The following is a description of a gene set: Human Gene Set: HP_MUSCLE_WEAKNESS Reduced strength of muscles. species: Homo sapiens Muscle weakness, and this is the list of marker genes: PMP22, NFE2L2, TBCD, EEF1A2, NEFH, ERCC8, PCNA, MINPP1, TRMU, TAF15, SGCG, SYNE1, VDR, TAMM41, MT-CO3, VWA1, BOLA3, DGUOK, HADHA, NABP1, ADSS1, CNBP, EARS2, GBF1, VARS2, SLC39A14, COL5A2, MEGF10, SMN1, SVIL, COL9A1, PRORP, WARS2, BTD, ITPR1, PNKP, XRCC1, SETX, NTNG2, MT-ND3, SOX10, NUP54, SLC1A2 (NCBI Gene Id 6506), RRAS, AARS1, ADGRG1, CYP27A1 (cytochrome P450 family 27 subfamily A member 1), MT-TL2, SORD, ERBB4, ALAS2, NF1, ARSA, DMP1, ABHD5, ACBD5, SZT2, AMER1, FXR1, CNTNAP1, PEX3, SLC25A1, PSMB8, OPA1, FAM111B, HTT, POMT1, COA8, TRPV4, BMP6, TFG, VMA21, MAP2K2, DPM2, TACR3, SPTLC1, DUX4, ARMC5, ATP7B, LIG3, DHDDS, IDS, ATP2A1, SLC12A3, MTM1, COL4A1, CNOT1, ABCD1, PEX19 (NCBI Gene Id 7835), LYRM7, CYP11B1, NDUFAF4, NDUFV1, C9orf72, GRIN1, MYOT, ABCA2, SLC2A3, COL6A3, TWNK, PIEZO2, MYH3, GNB1, FBXO28, TTPA, PLP1, MUSK, GRIA3, MTMR14, FUS, COL9A3, BVES, SLC25A26, CLCN1, NDE1, TNR (tenascin R), GFER, NTRK2, TRAPPC11, SGCA, PIGA, KCNJ18, PTS, PUS1, TCIRG1, POPDC3, LIMS2 (LIM zinc finger domain containing 2), NECAP1, FBLN5, TOP3A (DNA topoisomerase III alpha), TPM2, PGM2L1, CNKSR2, CLCNKA, KY, NDUFAF3 (NCBI Gene Id 375340), LYRM4, SLC5A6, SCN11A, LRP5, CDC73, LDB3, TRMT1, KCNJ2, UBA2 (NCBI Gene Id 10054), SFRP4, PLIN4, SURF1, BIN1, TREX1, TGFB1, ATP5F1D, SPR, GTPBP2, EBF3, ETFDH, COL1A1, SELENON, SLC12A1, SCNN1A, XYLT2, DSTYK (NCBI Gene Id 353293), MYF6, NEK1, EHHADH, MRAS, SLC25A19, ATRX, MT-ND5, RNASEH1, NIPA1, TRIM32, ATP5F1E, EXOSC9, HINT1, MYPN, MYBPC1, CRLF1, DUSP6, ERCC6, L1CAM, KCNE3, PIK3CA, AIFM1, TTN, MCM3AP, WDR11, GCH1, RXYLT1, MFN2, POLR3A, LRP4 (LDL receptor related protein 4), SLC12A6, NDP, FLAD1, SLC25A12, ZNF526, MFF (NCBI Gene Id 56947), DPAGT1, ACTL6B, EXOSC3, ATXN3, GNB5, MLX, EXOSC5, UQCRFS1, COL12A1, SUPT16H, CLTC, RUSC2, NKX2-1, FEZF1, MT-CO2, CPLANE1, RFXAP, MTTP, MYMX, GAN, SPTA1, UBQLN2, GOSR2, SCN2A, SMPD1, DPM3, DHH, GABBR2, BTNL2, AGTPBP1, PTEN, STAC3 (SH3 and cysteine rich domain 3), GDAP1, P4HA2, ETFA, PNPLA6, KCNC2, NONO, SCN8A, DES, PUF60, DNAJC19, TNFRSF11B, CACNA2D1, MTHFR, CHRNB1 (NCBI Gene Id 1140), KLHL41, PIGQ, SEPTIN9, FOXC2, CDKN2A, SPART, PDE11A, KMT2D, HSPB8, SLC7A7, GCK, OPTN, SOS1, POMGNT1, MT-TP, PEX2 (NCBI Gene Id 5828), TCAP, PEX26, ENPP1 (ectonucleotide pyrophosphatase/phosphodiesterase 1), DLL4, ANTXR1, CD59, SLC34A3, LAMP2, VRK1, OAT, NAA80, DNAJB2, GJC2, GSN, SPEG, ERLIN2, CYP27B1, ATP1A1, B4GALNT1, RRM2B, SACS, TEFM, AK9, EXTL3, SOS2, SIGMAR1, MT-TI, MT-TS2, SPG11, HCN1, LRP12, COQ8A, FXYD2 (FXYD domain containing ion transport regulator 2), IMPDH2, HNRNPA1, ACOX1 (acyl-CoA oxidase 1), EIF2AK3, CHRND, PI4KA, SPTLC2, PEX12, PRPS1, VPS50 (VPS50 subunit of EARP/GARPII complex), REEP1 (NCBI Gene Id 65055), ALS2, EMILIN1, DALRD3, DDC, HARS1, GFAP, POLG, CYP2R1, PPOX, MSTO1, HAMP, KARS1, GFPT1 (glutamine--fructose-6-phosphate transaminase 1), DKK1, DNA2, APTX, KIF1A, MTAP, SCYL1, GNAS, NFU1, KCNJ5, CCDC141, IL12B, PAX7, IRF4, NDUFS4, VARS1, NBN, MYL2, GAA, CLP1, LBR, CHRNE, SPG21 (NCBI Gene Id 51324), NUMA1, PEX10, DCC, SIK1, VCP, ALG13, MMUT (NCBI Gene Id 4594), CACNA1S, WWOX, SRPK3, NDUFAF2, MYL1, IBA57, SLC18A2, INPP5E (inositol polyphosphate-5-phosphatase E), HMBS, SCNN1G, MT-ATP6, PHEX, AAAS, COL13A1, FUCA1, VAMP1, SLC32A1, RAF1, KRAS, ANOS1, PHKA2, CAMLG, ARX, NARS2, ETFB, NDUFS7, CDK19, ATPAF2, MRPL12 (NCBI Gene Id 6182), DMPK, ABCB6, KLHL9, STAG2, PNPLA2, CACNA1B, REV3L, DAO, NDUFS3 (NCBI Gene Id 4722), PTRH2, CHCHD10, BMS1, TMEM63A, TIMM50, GABRA2 (gamma-aminobutyric acid type A receptor subunit alpha2), TMEM165, PEX5, ISCU, SRPX2, COX6A1 (cytochrome c oxidase subunit 6A1), SCYL2, NDUFAF5, TK2, RYR3, PABPN1, ACTA1, ATXN2, SLC26A4, COX6B1, SLC19A3, HS6ST1, CAPRIN1, SERPING1, COL9A2, CPT1C, EIF2B3, YME1L1, ATP13A2, PAFAH1B1, TTC19 (tetratricopeptide repeat domain 19), TPM3, KCNA1, PTPN11, RANBP2, IRAK1 (NCBI Gene Id 3654), GRM7, HACD1, NEUROD2, IFIH1, NEU1, PRPH, TCN2, ASCC1, TRAPPC6B, SECISBP2, SBF1, ANKH, KBTBD13, RNF170, PIGP, NOD2, ALDOA, POLRMT, SNAP29, ADAR (adenosine deaminase RNA specific), MRPS2 (NCBI Gene Id 64972), EIF2B2, UBA1, ADCY6, LIPE, FDX2, SDHAF1, CASQ1, AR, SLC13A5, TNNT1, SPRY4, PIK3R5, FBN1, MT-ND2 (mitochondrially encoded NADH:ubiquinone oxidoreductase core subunit 2), TBCE (NCBI Gene Id 6905), FLNC, TUBB6, SLC34A2, C19orf12, IRF5 (interferon regulatory factor 5), STIM1, HK1, MT-TN, STAT4, SPG7, ANO5 (anoctamin 5), SLC22A5, HSPD1, GPI, SAT1, POLG2, SYT2, POGLUT1, CCND1, NDRG1, CCM2, DARS2, SLC25A42, CYP7B1, NUBPL, BET1, SPARC, PEX7 (peroxisomal biogenesis factor 7), RALGAPA1, COQ2, CHRNA1, NDUFA10, COX6A2, ATXN1, PON1, D2HGDH, SIX5, CPLX1, TRPM7, RARA, FIP1L1, MRPS25, LARGE1, MICU1, FOXRED1, TRDN, PRNP, CCDC174, TTR, AGK, NR3C1, KIF5A, SIX1, HMGCR, CASR, MT-TQ, MT-ND1, SYNGAP1, RYR1, SEMA3A, IFRD1, GATM, GPHN, MT-ND6, MPZ, UQCC3, SLC9A7, TRMT5 (tRNA methyltransferase 5), DYM, MFSD2A, COA7, CYP11B2, TYMP, JAG1, SLC39A8, NDUFA1, CDH23, IREB2, CHP1, PDGFB, ESAM, SLC33A1, EMD, PHKG1 (NCBI Gene Id 5260), KCNJ10, FKRP, SUFU, DMD, CAPN3, GRIN2D, RFC1, MORC2, MT-ND4, HLA-DRB1, MEN1, BAG3, BRCC3, EPB42, SCN1A, ATP5F1A, AHDC1, GEMIN4, FRG1 (FSHD region gene 1), MT-TH, SGCD, MT-CO1, SLC16A2, NDUFAF6, COX20, TNXB, HESX1 (HESX homeobox 1), KCNJ1, RBCK1, MYMK, PPP1R15B, SNAP25, SMARCB1, MT-TE, FLI1, GARS1, CPOX, MPV17, CADM3 (NCBI Gene Id 57863), SNUPN, RETREG1, RARS1, SMCHD1, PTDSS1, PLOD1, PDXK, MYH7, RAPSN, PTPN22, RTN2, NOP56, PIGN, PSAP, TSFM, AGRN, SLC25A46, CAV3, PFN1, PRRT2, SUCLG1, GYG1, MECR, FIG4, ALAD, ADCY5 (adenylate cyclase 5), GABRB2, PHYH, HADHB, LTBP4, TRH, RASA2, CCR6, DHX16, IGHMBP2 (NCBI Gene Id 50985), MGME1, ASAH1, ATP1A2, SLC25A22, CYFIP2, TERT, SPAST, JAG2, PAX8, PYGM, PEX6, DSE, PEX13, NRAS, ADPRS, CDKL5, KPNA3, PDK3, TAFAZZIN, USP48, HEXB, COL25A1, AMPD1, PEX11B, SMN2, HNRNPK, CLDN16, ITGA7, BICD2, GNE, JPH1, IFT140, RAB7A, COL5A1, COQ7, WARS1, DNMT1, TPI1, FARS2, MT-ATP8, SLC25A20, KCNA2, COL1A2, MT-TK, ORAI1, STAT3 (NCBI Gene Id 6774), AARS2, PHKA1, AP3D1, ASPA, ACADM, GMPPB, GNA11, PHKG2, SARDH, RAI1, MT-TW, TDP1, NAGA, PHKB, PNKD, PLEKHG5, B3GALNT2, NDUFS8, PRX, TIMMDC1, BICRA, GGPS1, CASP2, COQ4, YARS1 (NCBI Gene Id 8565), SCO2, SLC25A24, FGD4, ATL1, MATR3, IL17RD, COX10, HEXA, NDUFV2, GABRA5, SLC25A21, HNRNPDL, SDHB, CHMP2B, DNM1, ATP9A, SYNE2, AKT1, NPM1, LRIF1, TSHR, PLXND1, PREPL, ACTN2, COG8, GFM2, HNRNPA2B1, CFAP410, LRSAM1, PET100, SARS1, HLA-B, PML, PMM2, UBAP1, SQSTM1, DNMT3B, CPT2, NF2, AHCY, PEX16, POMGNT2 (protein O-linked mannose N-acetylglucosaminyltransferase 2 (beta 1,4-)), NUTM2B-AS1, CHST14, NEB, PON3, ANG, AGL, SLC5A7, CASK, SMO, KLHL40, CAVIN1, SMPX, CNTN1, FKBP14, MTRFR, FGF17, HFE, TOR1AIP1, TRAF7, ASCC3, ITGB4 (integrin subunit beta 4), STAT5B, GJA1, CHD7, SPTAN1, PMPCA, TOR1A, TRAK1, PYROXD1, LGI4, PGAP2, GBE1, SUCLA2, ABCC8, SDHD, GLT8D1, GNB4, TBL1XR1, PON2, FZR1, SH3TC2, EGR2, STAT1, COL6A1, LAMA2, DOK7, SLC18A3 (solute carrier family 18 member A3), PTRHD1, PACS2, ATP13A3, CRYAB, NDUFA6, NDUFAF1, COL6A2, FGF23, SGCB, NDUFA11, SPTB, LITAF, TIA1, CCN6, VAPB, SOD1, VPS13D, KCNB1, TNPO3, LZTR1, LPIN1, GNB2, KRIT1, DYNC1H1, MYH2, ATP5MK, SMARCAL1, DNAJB6, NR4A2, COX4I1, ANK1, AFG3L2, RNU12, GRIN2A, NDUFB9 (NADH:ubiquinone oxidoreductase subunit B9), CACNA1A, SPTBN2, ADNP (activity dependent neuroprotector homeobox), ADK, PFKM, OSTM1 (NCBI Gene Id 28962), POMK, FLVCR1, INPP5K, HIVEP2, ATG7, CPT1A, RIT1, PGK1, SALL4, ELP2, SYNJ1, PMP2, LMOD3, MLIP, NDUFS6, DDHD2, NDUFS1, DCAF8, FA2H, SLC4A1, SNX10, XRCC2, TANGO2, PLA2G6, FGFR1, HPRT1, SBF2, ANXA11, AMPD3, NDUFAF8, CELF2, ASL, YY1, AP3B2, SOST, YWHAG, PGM1, CEP126 (centrosomal protein 126), EYA1, CBL, SHMT2, UFC1, VHL, TARDBP, DDHD1, POLR1A, POLR3GL, ZFTA, BCOR, KCNJ11, SPTBN4, CCN2, PLAA, LRPPRC, GJB1, AP2S1, ALG14, PMPCB, EXOC8, PROKR2, CTNNB1, POU3F4, ATXN7, SPP1, MME, TNNC2, KDM1A, NKX2-5, NDUFS2, PNPLA8, ATP6V1E1, ATP6V1A, UNC13A, CFL2, UBE2T, DNM2 (dynamin 2), DNAJB4, TRIM2, HLA-DQB1, CAMK2B, HSPB1, LMNB1, FGF8, RARS2, LAMB2, TFAP2A, BSCL2, ZNRF3, COQ6, HSD17B10, NDUFA13, RASA1 (NCBI Gene Id 5921), FGF12, UBA5, PDCD10, GNPTAB, FHL1, ACY1, MYO9A, TBCK, NDUFB10, PROK2, GABRA3, MAPT, FKTN, SEMA3E, MED25, BRAF, XK, CLCN7, COLQ, NACC1, ALG2, CCNF, RPS6KA3, CLCN2, ITPR3, MIEF2, DHTKD1, FBXL4, DCTN1, SPRED2, ALDH18A1, CACNA1G, ABHD16A, CHAT, BCS1L, PRKACA, ACAD9, TRIM8, SCN3A (NCBI Gene Id 6328), NDUFA8, ZFYVE26, WASHC5, SCN4A, PARS2, ATL3, RRAS2, IRF2BP2, UBE3B, NUS1, NAGLU (NCBI Gene Id 4669), FLRT3, ERGIC1, FOXG1, CHKB, SLC34A1, POMT2, SLC25A4, NOTCH2NLC, MDH2, MT-TV, VPS13A, MYH14, CAPN1, DAG1, MARS1, HOXB1, TBK1, SIL1, CLCNKB, OBSCN, FXN, B4GAT1, TUBB3, TMEM126B (NCBI Gene Id 95018), FMR1, SLC38A3, FBXO38, SDHA, ZBTB16, DOLK, UNC45B, DYSF, USP8, TMEM43, SLC35A2, AP5Z1 (NCBI Gene Id 9907), GBA2 (glucosylceramidase beta 2), EXOSC8, KIF1B, SLC52A3, DUX4L1, NADK2, RNF31, BSND, MT-TF, PNPT1, MICOS13, TREM2, NDUFB11, PPP3CA, KLHL24, HSPB3, FOXE1, NUP62, NDUFB3, TRMT10A, GABRG2, TRIP4 (NCBI Gene Id 9325), HJV, PEX1, CAV1, CNNM2, ZC4H2, LEMD2, HSPG2, DHFR, DMXL2, ATP5MC3, GLE1, ATP7A (ATPase copper transporting alpha), YARS2, MTMR2, PEX14, PLEC, GALC, ELOVL5, GM2A, NSUN3, CCDC78, SKI, SMARCE1 (NCBI Gene Id 6605), SLC52A2, GIPC1, FILIP1, NGLY1, SCNN1B, NDNF, ABCA1, BAP1, PRKAR1A (protein kinase cAMP-dependent type I regulatory subunit alpha), PHACTR1, ADA2, TGM6, NEFL, KCNK9 (NCBI Gene Id 51305), RRM1, MB, PIGF, MAP3K20, ATP1A3, MT-TL1, ACADVL, TOE1, SCN1B, PPARGC1A, LMNA, LYST, GNAO1, HYCC1, PCLO, INF2, RILPL1, CRPPA, TP53